Given this list of marker genes Htr4, Drd3, Alk, Htr2b, Gper1, Htt, Ncstn, Taar1, Rgs4, Adcy6, Gnb5, Gm527, Vps35, Htr3b, Nr4a3, Nherf1, Gnai3, Oprm1, Rgs8, Htr7, App, Gna15, Ptger1, Palm, Drd2, Htr1a, Oprd1, Htr2c, Drd1, Tgm2, Dtnbp1, Htr3a, Hcn3, Flna, Htr6, Slc1a1, Drd5, Htr2a, Gna11, Adcy5, Gnaq, Sin3a, Gnal, Aplp1, Prmt5, Rgs9, Gnao1 (NCBI Gene Id 14681), Klf16, Gna14, Dnm2, Gnas, Cav2, Lrrk2, Drd4, Prkd1, here is a description of the gene set: studied in species Mus musculus Any process that results in a change in state or activity of a cell (in terms of movement, secretion, enzyme production, gene expression, etc.) as a result of a monoamine stimulus. A monoamine is any of a group of molecular messengers that contain one amino group that is connected to an aromatic ring by ethylene group (-CH2-CH2-). Monoamines are derived from the aromatic amino acids phenylalanine, tyrosine, histidine and tryptophan. Mouse Gene Set: GOBP_CELLULAR_RESPONSE_TO_MONOAMINE_STIMULUS